The following is a description of a gene set: Genes down-regulated in comparison of virus specific (gp33) exhausted CD8 T cells versus the virus specific (gp276) cells. CD8 T cells normally differentiate from resting naïve T cells into function effector and then memory CD8 T cells following acute infections. During chronic viral infections, however, virus-specific CD8 T cells often become exhausted. We used microarrays to examine the gene expression differences between naive, effector, memory and exhausted virus-specific CD8 T cells following lymphocytic choriomeningitis virus infection. from publication Wherry EJ, Ha SJ, Kaech SM, Haining WN, Sarkar S, Kalia V, Subramaniam S, Blattman JN, Barber DL, Ahmed R (PMID 17950003) Human Gene Set: GSE9650_GP33_VS_GP276_LCMV_SPECIFIC_EXHAUSTED_CD8_TCELL_DN studied in species Homo sapiens, and this is the list of marker genes: CDCA8, SLC23A2, RAD17, SLC35A1, LDAH, CALU, TBC1D14, ARIH2, PDK1, PITHD1, ZBTB25, RBMXL1, HIKESHI, RNF34, HSD11B1, CHP1, RNF13, PIAS3, SEC61A2, TXNL4A, HNRNPM, PIK3CA, ARMC1, ELAVL1, DUSP19, SLC7A6, SMIM20, PLEKHB2, ABCE1, DSC1, PDE7A, METTL9, IVNS1ABP, ITGAL, RABEPK, R3HDM1, DPP3, SDHA, GLO1, TAF11, SELENOH, PPM1B, MLX, BMAL1, GINM1, CCNDBP1, TM9SF2, HCLS1, SNX1, PSAT1, ANXA5, PUF60, HADHB, WSB2, ARIH1, NAE1, MRPS33, VDAC3 (NCBI Gene Id 7419), MSH2 (NCBI Gene Id 8169), PLRG1, YIF1A, URM1, C9orf78, RNF2, PNPT1, TMEM50B, WNT10A, PAK2, SGTA, NDUFAF1, ANAPC16, PPA1, CIRBP, BCL2L11, DESI1, PRKAB1, TIMM44, STK38, SLC39A9, PSMD13 (proteasome 26S subunit, non-ATPase 13), SWI5, RNPS1, MCEE, IL10, LMAN1, TGIF2, DNAJC9, TWF2, SLC25A20, BLMH, RAB2A, HADH, EIF1, AKIRIN1, GALK2, KLF3, ATF6 (activating transcription factor 6), NUTF2, NAA10, SLC1A5, WTAP, NTAN1, GHITM, PLS3, PITPNC1, FAHD1, LEF1, VPS25, TMEM45A, RBM18, EDEM1, TIAM1, LAMTOR5, ITPA, UBALD2, NFKBIZ, TMEM223, TADA1, SNAPIN, ZDHHC6, SEMA4A, TIPRL, LY75, JKAMP, GGPS1, FUCA1, IKBKG, NUDT1, CTNNB1, FRMD6, HMBS, SMU1, EIF2S1, FOXO3 (NCBI Gene Id 2309), GLIPR2, UTP14A, SSNA1, ARMC10, CIAO2A, TMEM168, CCT4, ORC5, FOXRED1, MIEN1, SGK1, GTF3A, HNRNPAB, NDUFS1, SPTLC1, SRP68 (signal recognition particle 68), SRPK1, SAT1, CXorf38, BBLN, DNM1, DAP, SEH1L, SMARCB1, TOP3B, C6orf120, PPM1G, RNASEH1, U2AF1, COPS5, GRIK1, XRCC6, EIF2B5, LATS2, ZIC2, STX6, CYC1, PPP2R1B, HBB, PRIM2, TIA1, AP3M1, DERL2, KLRC1, HMCES, PAFAH1B2 (NCBI Gene Id 5049), DUSP1, POLR2M, CAMLG, CLNS1A, SNIP1, AP1M1, TIMM22, IL10RA (NCBI Gene Id 3587), PTTG1, SAE1, INTS7, UBP1, PRKCH, TNPO1, SLC30A9, SACM1L, CLP1, IGSF10 (immunoglobulin superfamily member 10), SLC4A7, KLHDC2